Given this list of marker genes SMIM14, PKIB, CCDC28B, CTSS, NUCB2, CD79B, VPS35, IREB2, ADAM9, PDE8A, PLBD1, UPF3B, POU2AF1, NHSL2, ADCK1, MFHAS1, BLZF1, ERP29, TIPARP, POLR2A, FICD, ARRB1, MTPN, BCL2L2, MCOLN2, SBDS, GCM2, DNAJB9, MGAT1 (NCBI Gene Id 4245), RNGTT, GABPA, LGMN, GPR137B, CMTR2, CASP1, PSMD14, PEPD, GNS, RYR1 (NCBI Gene Id 906), RAB35, HLA-DQA1, WBP2, LYL1, KLHL7, SUCLG2, CIC (capicua transcriptional repressor), RUFY1, SND1, NCF4, PRKCE, RNF13, ABCF3, VPS41, SYK, NHSL3, LY6D, DCAF1, CLTC, GGA2, ZNF385A, CD2, VCL, LYN, EPS15, ZC3H12C, CHD1, HLA-DOB, KIF9, SNX2, ELL2, ASNSD1, FAM91A1, ILF3, VKORC1, SLC7A7, SYT2, SERINC3, LMO2, B4GALT6, IQGAP1, MCL1, IFI30, TPST1, STX7, SAFB, RAB14, RALGPS2, NAPSA, DAG1, KLF4, UBL3, SLC25A15 (NCBI Gene Id 3089), CD2AP, HHEX, PLAC8, ADM, RHOQ, PBX3, CD74, GNG10, TUBB6, TXNDC16, TCF4, SAA1, MS4A1, STK25, CEACAM21, HLA-DMA, SCOC, TSPAN32, RNF181, ZSCAN26, CTSH, CNN3, CD19, SPI1, LIMD1, TPD52, CEP89, MPEG1, PLD4 (NCBI Gene Id 414770), ERO1B (endoplasmic reticulum oxidoreductase 1 beta), SSPN, NDEL1, BTK, FCRLA, CBFA2T2, UIMC1, PRKCD, RPGR, CTSZ (cathepsin Z), NID1, POU2F1 (POU class 2 homeobox 1), MYADM, PPID, CYFIP1, TMEM123, D2HGDH, PKIG, VPS4B, SELL, PPP1R21, BLNK, ASH1L, TEC, IRF5, RAB10, C6orf89, PSAP, PTS, CHUK (NCBI Gene Id 1147), APOBEC1, KLC1, IL18, SPIB, DPF2, PON3, ZNF207, DIDO1, SEPTIN2, CXCR5, HCK, NUDT19, IGHM, WDFY2, IGLC7, ITGA6, CFAP20, SNX5, FEM1A, C9orf85, RB1, EIF2AK4, HSD17B11, CD40, INPPL1, GBP4, DRAM2, ALOX15 (arachidonate 15-lipoxygenase), CXCL13, MEF2C, ZNF106, ENTPD1, TRMT1, MAPK12, PHTF2, SNX10, TEP1, TUBB2A, AOPEP, TMOD3, IRF3, UBE2G1, CAMLG, LMO7, OAT, TBC1D14, BCL7B, PRKCB, MIF4GD (NCBI Gene Id 57409), here is a description of the gene set: Genes up-regulated in CD8 T cells: KLRB1 high versus KLRB1 int. This SuperSeries is composed of the SubSeries listed below. Human Gene Set: GSE33425_CD161_HIGH_VS_INT_CD8_TCELL_UP species: Homo sapiens from publication Walker LJ, Kang YH, Smith MO, Tharmalingham H, Ramamurthy N, Fleming VM, Sahgal N, Leslie A, Oo Y, Geremia A, Scriba TJ, Hanekom WA, Lauer GM, Lantz O, Adams DH, Powrie F, Barnes E, Klenerman P (PMID 22086415)